Given this list of marker genes STK24-AS1, STK24, NPAS1, TMEM229A, INSYN1, NR2F6, TSC22D2, MTND5P11, here is a description of the gene set: Human Gene Set: PBRM1_TARGET_GENES from publication Yevshin I, Sharipov R, Kolmykov S, Kondrakhin Y, Kolpakov F (PMID 30445619) species: Homo sapiens Genes containing one or more binding sites for (PBRM1) in their promoter regions (TSS -1000,+100 bp) as identified by GTRD version 20.06 ChIP-seq harmonization.